The following is a description of a gene set: studied in species Homo sapiens To elucidate gene expression pathways underlying age-associated impairment in influenza vaccine response, we screened young (age 21-30) and older (age >= 65) adults receiving influenza vaccine in two consecutive seasons and identified those with strong or absent response to vaccine, including a subset of older adults meeting criteria for frailty. PBMCs obtained prior to vaccination (Day 0) and at day 2 or 4, day 7 and day 28 post-vaccine were subjected to gene expression microarray analysis. We defined a response signature and also detected induction of a type I interferon response at day 2 and a plasma cell signature at day 7 post-vaccine in young responders. The response signature was dysregulated in older adults, with the plasma cell signature induced at day 2, and was never induced in frail subjects (who were all non-responders). We also identified a mitochondrial signature in young vaccine responders containing genes mediating mitochondrial biogenesis and oxidative phosphorylation that was consistent in two different vaccine seasons and verified by analyses of mitochondrial content and protein expression. These results represent the first genome-wide transcriptional profiling analysis of age-associated dynamics following influenza vaccination, and implicate changes in mitochondrial biogenesis and function as a critical factor in human vaccine responsiveness. Genes down-regulated in peripheral blood mononuclear cell 28d vs 0d in young adults (21-30) (nonresponder) after exposure to Inactivated influenza vaccine, time point 28D Human Gene Set: THAKAR_PBMC_INACTIVATED_INFLUENZA_AGE_21_30YO_NONRESPONDER_28DY_DN from publication Thakar J, Mohanty S, West AP, Joshi SR, Ueda I, Wilson J, Meng H, Blevins TP, Tsang S, Trentalange M, Siconolfi B, Park K, Gill TM, Belshe RB, Kaech SM, Shadel GS, Kleinstein SH, Shaw AC (PMID 25596819), and this is the list of marker genes: SDF4 (NCBI Gene Id 82832), BHLHE40, TNFSF12, SNORD35B, CBX4, SNORD68, CSAD, IL32, MIAT, FUBP3, NXF1, WDFY2, EXOSC2, NDUFB4, SNORA64, WWP2, VPS52, ZFHX3, SLCO3A1, FLII, RNASEH1, SLC3A2, MAF (NCBI Gene Id 4094), ATG4B, SLC35B2, RAP1GAP2, NPIPA1, STAT6, ADGRL1, SCAND1, PNPLA6, ENTPD4, DCAF7, CES2, S100A10, PNKP, HLA-C, ZNF362, PITPNM1, PLOD3, GTF3C1, GUSB, CIDEB, ITGAL, SNORD4A (small nucleolar RNA, C/D box 4A), TM9SF4, TOGARAM2, YPEL2, FYN, ITGB2, ENTPD6, EIF4H, ZYX, OSBPL7, RANBP3, SLFN13, SF1, TTLL3, SRPK2, COMT, SDE2, RHOT2, RPL10, ATP2A2